The following is a description of a gene set: species: Homo sapiens Human Gene Set: HP_ABNORMALITY_OF_THE_HYPOTHENAR_EMINENCE Abnormality of the hypothenar eminence An abnormality of the hypothenar eminence, i.e., of the muscles on the ulnar side of the palm of the hand (i.e., on the side of the little finger)., and this is the list of marker genes: AAAS (NCBI Gene Id 8086), RPL11, EIF4A3, GMPPA, TBX5, TRAPPC11, FGD4